The following is a description of a gene set: Human Gene Set: GOBP_CELLULAR_RESPONSE_TO_TOPOLOGICALLY_INCORRECT_PROTEIN species: Homo sapiens Any process that results in a change in state or activity of a cell (in terms of movement, secretion, enzyme production, gene expression, etc.) as a result of a protein that is not folded in its correct three-dimensional structure., and this is the list of marker genes: PTPN2, VCP, RHBDD2, DDRGK1 (NCBI Gene Id 65992), AKT3, ASB11, TMBIM6, ATF6B, AKT2, HSPA1A, UBR5, UBE2W, PRKN, CREBZF, FICD, OPTN, RACK1, EDEM3, FUT1, CAV1, ERN1, UBR4, PARP16, SELENOS, SDF2L1, EDEM2, UFL1, SERP2, RNF7, PARP6, UFD1, DERL1, DAXX, ERMP1, DERL2, MIR199A1, TMBIM4, ATAD3A, HSPA5, BFAR, NFE2L2, AKT1, MBTPS1, SERP1, ATF6, UMOD, KLHL15, TM7SF3, WFS1, HERPUD2, CREBRF, BHLHA15, ATF4, YOD1, DERL3, COPS5, BOK, CUL3, DDIT3, PIK3R1, AGR2, XBP1, CDK5RAP3, PIGBOS1, DNAJB12, PACRG, QRICH1, RNF126, TBL2, PPP1R15A, ERLEC1, RPAP2, EIF2AK2, AKIRIN2, TMTC4, ABCA7, BAK1, PARP8, VAPB (NCBI Gene Id 9217), ATF3, BAG3, RHBDD1, DNAJC18, CREB3, BCL2L11, HERPUD1, DNAJC10, CREB3L1, HSF1, TMED2, HSPB8 (NCBI Gene Id 8097), BAX, PPP1R15B, CTH, HSPD1, NCK1, HDAC6, DAB2IP, BBC3 (NCBI Gene Id 27113), ABCB10, TMEM33, ERO1A, STUB1, DNAJB9 (DnaJ heat shock protein family (Hsp40) member B9), OS9, MANF, EIF2S1, CCND1, DNAJB14, NCK2, ERN2, MBTPS2, AMFR, STC2, EIF2AK3, ATXN3, PTPN1